The following is a description of a gene set: species: Homo sapiens Periodic (episodic or recurrent) bouts of fever. Human Gene Set: HP_RECURRENT_FEVER Recurrent fever, and this is the list of marker genes: UBAC2, HLA-B, STING1, H4C5, REL, MCTS1, STX11, DPP9, SLC35C1, MVK, CYP11B2, PEX6 (NCBI Gene Id 5190), LIFR, ALPK1, OFD1, PSMB8, PTS, SLC41A1, DOCK2, RIPK1, IL2RG, PMP22, CEBPE, CBLB, SHARPIN, C2orf69, WDR1, HBB, GCH1, DNASE2, PRKCD, TLR4, MEFV, COG6, TNFRSF1A (TNF receptor superfamily member 1A), PTPN6, QDPR, ELANE, ERAP1, DEF6, CRLF1, STAT2, NLRP12, COG7, IL23R, FAS, IL10, NAXD, RBCK1, ADA2, IFNGR1, FOCAD, STXBP2, ATP5F1B, ITK, SYK, ZFHX2, PRF1, CCR1, TBK1, SPTBN1, ORAI1, ADA, PSMG2, HEPHL1, CD70, IFIH1, RNF31, SLC19A1, TLR7 (NCBI Gene Id 51284), SLC29A3, NLRP1, OTULIN, LACC1 (NCBI Gene Id 144811), CYP21A2, STIM1, NLRP3, ASAH1, STAT4, IL12A, STK4, SLC12A3, NLRC4, IL12A-AS1, GALC, UBA1, HNRNPK, C3, NTRK1, C4A (complement C4A (Chido/Rodgers blood group)), RNF168, IBA57, RNU4ATAC, NGF, XIAP, ELF4, ELP1, LPIN2, ZNFX1, BCAP31, NOD2, TRNT1, PSMB4, KLRC4, TNFAIP3, SH2D1A